Given this list of marker genes RAD1, ZWINT, NSUN2, KNL1, HUS1B, HORMAD1, CHFR, TRIP13, HUS1, TTK, here is a description of the gene set: A signaling process that contributes to a meiotic cell cycle checkpoint that ensures accurate chromosome replication and segregation by preventing progression through a meiotic cell cycle until conditions are suitable for the cell to proceed to the next stage. Human Gene Set: GOBP_MEIOTIC_CELL_CYCLE_CHECKPOINT_SIGNALING species: Homo sapiens